The following is a description of a gene set: studied in species Mus musculus part of: Peptide ligand-binding receptors Reactome Pathway: Vasopressin-like receptors electronically inferred by orthology from the curated human pathway This event has been computationally inferred from an event that has been demonstrated in another species.<p>The inference is based on the homology mapping from PANTHER. Briefly, reactions for which all involved PhysicalEntities (in input, output and catalyst) have a mapped orthologue/paralogue (for complexes at least 75% of components must have a mapping) are inferred to the other species., and this is the list of marker genes: Avpr1b, Avp, Oxtr, Avpr2, Oxt, Avpr1a